The following is a description of a gene set: studied in species Homo sapiens from publication La Manno G, Gyllborg D, Codeluppi S, Nishimura K, Salto C, Zeisel A, Borm LE, Stott SRW, Toledo EM, Villaescusa JC, Lönnerberg P, Ryge J, Barker RA, Arenas E, Linnarsson S (PMID 27716510) Cell types are named using anatomical and functional mnemonics prefixed by 'm' or'h' to indicate mouse and human respectively: OMTN, oculomotor and trochlear nucleus; Sert, serotonergic; NbM, medial neuroblast; NbDA, neuroblast dopaminergic; DA0-2, dopaminergic neurons; RN, red nucleus; Gaba1-2, GABAergic neurons; mNbL1-2, lateral neuroblasts; NbML1-5, mediolateral neuroblasts; NProg, neuronal progenitor; Prog, progenitor medial floorplate (FPM), lateral floorplate (FPL), midline (M), basal plate (BP); Rgl1-3, radial glia-like cells; Mgl, microglia; Endo, endothelial cells; Peric, pericytes; Epend, ependymal; OPC, oligodendrocyte precursor cells. Human Gene Set: MANNO_MIDBRAIN_NEUROTYPES_HRGL1, and this is the list of marker genes: LHX3, LRRC17, TSPAN11, PEA15, ARHGAP5, MSI1, ATP2B2, CCND2-AS1, CELSR1, TSPAN18, GCA, CBLN4, HBG1, TCF12, HBA1, TSHR (NCBI Gene Id 7253), CROT, CSPG5, B3GLCT, RFTN2, TFF3, KLF15, DCN, DYNLT5, FAT3, HBG2, ARHGAP5-AS1, TGIF2, YAP1, C6orf118, ECEL1, LRRN2, ODAD3, CFAP44, SOX6, HBA2, ITPKB, GULP1, ZBTB2, WFS1, FGFR3, TMEM231, TMEM123, PON2, CHN2, ENKUR, PBXIP1 (PBX homeobox interacting protein 1), HOATZ, LMCD1, APCDD1, RGS4, CRB2, MLF1, FOXJ1, SLIT2, VIM, PLTP, ELOVL1, IGFBP2, EEPD1, PXDC1, LHFPL6, C1orf226, LMX1A, KCNG1, VIT, PLEKHA5, TENM3 (NCBI Gene Id 55996), GFOD3P, CRYAB, CDK6, IL18, COL23A1, FOXM1, GPM6B, ZC3H12C, CFAP90, MGST1, NPNT, TF (NCBI Gene Id 7018), BMP7, DENND2B, FOXA1, GRIK1, COL21A1, EVI5, ID4 (NCBI Gene Id 3400), NFIA, PALS1, DNAH7, CDO1, SPAG6, BMP6, CIMAP3, AASS, DCDC1, WNT7B, B3GNT5, FRZB, RAB2A, NOTCH1, SOX21 (SRY-box transcription factor 21), SULF2, WSCD1, CCDC17, INHBB, SLC25A18, FOXP2, DACH1, SPAG1, WLS, RHOJ, COL4A5, TRAM2, CFAP45, BLVRB, CEP126, SCN1A, FABP7, DSG2, SHISAL1 (NCBI Gene Id 85352), MORN2, PMP22, MPPED2, PIK3IP1, HEY1, CREB5, WEE1, LTBP1, SLIT1, ZFP36L1, RPGR, MIR99AHG, LGI1, RTKN2, IRS1, SERTM1, PTPRO, IGSF1, GDPD2, TES, PRTG, TPBG, FREM2, FRMPD2 (NCBI Gene Id 414180), TTYH1, FNDC1, SERTAD4, ZBBX, YBX3, EPHB4, KCNN3, MED12L, RSPH1, PPIL6 (NCBI Gene Id 285755), PREX1 (phosphatidylinositol-3,4,5-trisphosphate dependent Rac exchange factor 1), PARD3B, PDE11A, SHROOM3, VWA3A, QKI, FJX1, ATXN1, PSD3, CCDC181, LRRIQ1, SPEF1 (NCBI Gene Id 25876), IFI6 (NCBI Gene Id 2537), HEPACAM, AQP4, TTC29, HES1, PDGFC, TENM4, LRP8, TMEM218, COL18A1, NPTX2, CCN1, HES5, ARX, EFHC2, SLC19A2, INTU, NEK11, SOX2, GLIS3, OTX2, ID3, LIPG, AFF1, LRRC37A3, KLHDC8A, MOK, NFATC2, ANTXR1, KMT2E-AS1 (KMT2E antisense RNA 1), PLP1, TMEM47, HK2 (hexokinase 2), IGDCC4, STON2, TMEM132C, ELN, ZFP36L2, SCD, CXCL2, GASK1B (NCBI Gene Id 83936), S1PR1, CTDSP1, TTK, CRYL1, BCAN (brevican), SOX9, NES, STON1, PDLIM5, CLU, ECHDC2, PDLIM3, FOXA2, NINJ1, CPNE2, NCKAP5, ARMC3, WNT1, IL33, TRIM9, RGMA, EPCIP, ASIC3, TSC22D4, RMST, SLC16A9, FRMD3, WNT8B, ACSS1, BCO2, NXPH1 (neurexophilin 1), CFAP144, CFAP210, CADM3, IGDCC3, ARHGEF26, VSTM4, WNT5A, MNS1, LRRTM3, CLXN, TRIM59, FZD1, C8orf34, FLVCR2, PLIN3, FAT2, SAMD13, IQCG, MORN5, LAMB2, ZGLP1 (zinc finger GATA like protein 1), CDC25C, GABPB2, JAM2, IQCA1, DDAH1, TMPRSS5, KIAA1549L, TRABD2A, ERMN (ermin), MSX1, TWIST1, SMYD3, REST, LRP2BP, PDPN, DNAH6, CD44, OPHN1, CSPP1, ERF, STOM, NEBL, EFHD2, NUAK2, TACR1, RSPO2, ROPN1L, GPRC5C, RFX4, IQANK1, CCDC39, FLNC, NRBP2, NKD1, PDE3A, TNFRSF11B, MAML2, HEATR5A, CHST3, KLHDC8B, PDE1A, ERBB4, FAT1, DTX4, LYPD1, RIDA, RSPH9, DNAAF1, FSTL5, ILDR2, CEMIP2, NFIB, CFAP77, PSAT1 (phosphoserine aminotransferase 1), ARHGEF26-AS1, DOK5, CDON, SNTG1 (NCBI Gene Id 54212), CCN2, CFAP126, NTS, RNF182, SPAG17, DIPK2A, CAP2, XPO4, PTK2B, RCN1, ZNF474, TBC1D32, TEKT1, PLSCR4, FAM216B, NPR3, SOX5, ITGB8, ITPRID2, VEPH1 (ventricular zone expressed PH domain containing 1), CCDC146, GPC4, BRCA1, ZNF682, RAI14, TAGLN2, DEPTOR, NACC2, LRATD2, TSIX, GNG12, DNAJB4, SPMIP6, CFAP299, NDNF, HYDIN, NUDT4 (nudix hydrolase 4), NOTCH2, NKAIN4, ADAMTS6, DMRTA2, IGFBP5 (NCBI Gene Id 3488), PLOD2, ADGRV1, AHNAK, FZD6